Given this list of marker genes PHLDA3, RNVU1-15, GTPBP3, CACUL1, TSNAX, EPC1-AS2, MTCO3P12, SHISA8, FAM228B, FGD4, FAM230G, SDF2, SUPT6H, ZNF461, PAXBP1, UNC13A, ZNF221, IRGQ, CCDC18-AS1, HEY1, NOP56, EPCIP-AS1, MTND5P11, ERGIC3, RNF19A, EPC1-AS1, PCF11-AS1, PAPSS1 (NCBI Gene Id 9061), CITED1, DAND5, ARK2C, PLEKHH2, ANO8, DR1, SUCO, PFN4, here is a description of the gene set: Human Gene Set: ZNF502_TARGET_GENES from publication Yevshin I, Sharipov R, Kolmykov S, Kondrakhin Y, Kolpakov F (PMID 30445619) studied in species Homo sapiens Genes containing one or more binding sites for (ZNF502) in their promoter regions (TSS -1000,+100 bp) as identified by GTRD version 20.06 ChIP-seq harmonization.